Given this list of marker genes PCBP1-AS1, LINC01732, TIMM50, NTPCR, ALDH5A1, SAMD9L, IGFL2-AS1, ACBD5, LINC00824, LRRC61, UTP11, EOGT, PSMA3-AS1, RPF1, OPLAH, ZSCAN31, ANKRD65, ENSG00000268460, RBBP4, AFF4, SNORD3J, LINC02985, ASAP3, SEC14L1, HISLA, RIN3, BAZ2B-AS1, LINC02252, TULP2, NAGLU, UBA5, PRKAR1B-AS1, WSB1, ARID4A, ARMH4, ZBTB8OS, IFI27, CMTM3 (NCBI Gene Id 123920), ZNF8, RNU1-108P, LINC00964, NBPF12, CCDC137, TBX6, LSM10, PIP4K2A, CCDC136, DHRSX, VPS29, ERI1, RAD9B, PPP4R1L, TCERG1, CARD8, UFL1, LEPROTL1, TMEM14B, STAP2, TRMT12, ATF7IP2, SLC34A1, PRKAR1B, TMEM161B, ZNF8-ERVK3-1, SNHG20, MPND, PCAT14, GTF2IRD1, C6orf89, ZFYVE1, KCNAB1, MAK16, P4HB, NOSIP, GNG4, UCA1, MIR4766, ENSG00000221040, STRIP1, DHX40, ENSG00000255491, VDAC2, WBP1L, CARD8-AS1, SYF2, H3-3B, LINC02842, SEC24C, ZFAT, IKBKB-DT, CLPX, CPNE2, here is a description of the gene set: Human Gene Set: CAVIN1_TARGET_GENES studied in species Homo sapiens from publication Yevshin I, Sharipov R, Kolmykov S, Kondrakhin Y, Kolpakov F (PMID 30445619) Genes containing one or more binding sites for (CAVIN1) in their promoter regions (TSS -1000,+100 bp) as identified by GTRD version 20.06 ChIP-seq harmonization.